The following is a description of a gene set: Human Gene Set: HP_ABNORMAL_CONJUGATE_EYE_MOVEMENT Abnormal conjugate eye movement species: Homo sapiens Any deviation from the normal motor coordination of the eyes that allows for bilateral fixation on a single object., and this is the list of marker genes: GP1BB, ALDH3A2, MAB21L1, RPS26, SOST, FOXRED1, DDX3X, ADSL, METTL27, RRM2B, CDCA7, TGFBR2, NOP56, HECW2, FLNA, LRAT, HADHA, WT1, CACNA1B, KRT10, FGF10, ARL6, UBE3B, UBE2A (ubiquitin conjugating enzyme E2 A), INTS11, COL2A1, ADPRS, MAFB, HACE1, KCNAB2, ATP1A2, PIK3R1, MID1, MDH2, HYLS1, VPS53, TMEM222, SEC23A, POLG, ROR2, PURA, WDR45, EXOSC8, PSMC3, NOG, PTEN (phosphatase and tensin homolog), ATAD3A, FANCD2, NONO (NCBI Gene Id 8253), RHO, EIF4H, NBAS, GAS1, GJA1, BBS1, KRT74, TBCD, DLK1, GTF2I, MT-ND3, MAB21L2, TAF1, MEG3, CDON, NSDHL, AGRN, KANSL1, MRPS34, SUCLA2, DCC, FKTN, PEX13, WARS2, RBM8A, ATIC, GJA8, GRM1, RET, SLC12A6, CEP41, DLL1, POLR1C, FBLN5 (NCBI Gene Id 11268), PHF21A, ADAMTS15, DOCK6, PIGQ, MT-ND1, BCL11A, VPS50, GAN, WDPCP (WD repeat containing planar cell polarity effector), GALNT2, BCOR, NDUFB9, TBC1D7, ATP6V1A, ANAPC7, MED11, HDAC8 (histone deacetylase 8), SNRPN, PEX19, H4C9, PEX11B, GNA14, RBPJ, HOXA1, BCAP31, SON, ASXL3, EP300, BBS10, HMGB3, ACBD6, NT5C2, NDST1, ATR, PALB2, SLC37A4, NDUFB11, MPDU1, PPP1R21, RPL31, GALC, FANCB, MED13, TRPM3, SRPK3, MT-ATP8, NIPBL, POLR3B, CPLANE1, EXT2, DCTN1, IFT172, DPF2, CHN1, NAGA, AIMP1 (NCBI Gene Id 9255), GRIN1, NR2F1, SOS2, ADAT3, CACNA1F, CHAMP1, SLC24A1, NSMF, PIGV, HOXA13, AHCY, ARHGAP31, MAPT, CFAP418, SCLT1, CASK, SCN4A, GNB1, BRCA2, TAF2, UFD1, RNF113A, LARGE1, HNRNPH1, TMEM67, LYRM7, TRIM32, DHX37, BICRA (NCBI Gene Id 29998), RPL9, SLC1A3, CEP19, EHMT1, EIF2S3, CLTRN, BLOC1S3, CAPRIN1, TTI1, SMARCB1, ALDH1A3, COLEC11, FOXL2, SIK1, IDH3A, AHDC1, LRRC32, PRDM16, POU3F4, NDUFS8, KDM5B, DGUOK, HSPG2, PEX3, B9D2, UBA2, EZH2, CLTCL1, SYNE1, SLC9A7, CDH3, SETX, ERI1, SLC6A8, ARVCF, PIBF1, LCA5, CLDN16, ZFX, RIC1, VPS51, CDH2, SIGMAR1, PRSS56, SCAF4, TARDBP, NDUFAF5, PHOX2B, SPTLC1, SCAPER, NOTCH1, AARS1, COG8, RPGRIP1, NDUFS3, GDF5, VCP, FMR1 (fragile X messenger ribonucleoprotein 1), ROBO1, PIGL, TBC1D24, MKS1, ATCAY, PRMT7, KAT8, MYH3, ATP9A, RAI1, MFRP, MN1, ANKH, PEX12, H4C11, MED25, PTPN11, FANCC, IGF1R, KDM6A (NCBI Gene Id 7403), SATB2, NF1, RASA2, CLCN4, NDUFAF8, STRADA, BRPF1, HOXB1, ACOX1, GNB3, XRCC2, SOX3, NDUFA1, NHLRC2, UBE4B, RPL35A, VPS13B, RERE, PEX16, GJA5, ATOH7, RAX (retina and anterior neural fold homeobox), XPC, CYB5R3, PRKAR1B (NCBI Gene Id 645590), MT-ND2, RPL27, ALG2, CRPPA, DEAF1, FOXC1, BMP4, GFPT1, ADD3, TCTN3, RPS27, COL8A2, FKRP, AP3D1, TMEM63C (NCBI Gene Id 57156), BBS4 (NCBI Gene Id 585), DDHD2, PEX2, GRID2, POMK, MKRN3, MAP2K2, NRAS, HPS3, SBF1, DACT1, BBS7, SIL1, MADD, NDUFS2, FARS2, SREBF1, SPTAN1, POLR1D, GPR143, CTBP1, ABCB7, DNMT3A, NRXN1 (NCBI Gene Id 9378), SNIP1, SPEN, CEP85L (centrosomal protein 85 like), ROBO3, SMC1A, PDE6B, NRCAM, TRIP12, SALL4, CACNA2D4, TCF4, U2AF2, AGTPBP1, RPE65, CLCN6, NDUFAF2, CDC42BPB, PCYT1A, PRNP, INPP5K, SMAD3, PIGW, NPAP1, ALG9, UBE3A, IRF2BPL, SEC24C, TASP1, DLL4, ANKRD11, ACO2, TCF20, RPS20 (ribosomal protein S20), HERC2, ALDH18A1, RP1L1, SCN8A, CHD6, EBF3 (NCBI Gene Id 276717), PAX6 (NCBI Gene Id 5080), VRK1, SHANK3, TBX4, ELOVL4, FUS, ASH1L, LAMB2, NSUN2, TEFM, ADAMTS3, PMM2, RAD21, CHRNG, PRKACA, PAH, PTRH2, GLI1, AMMECR1, KCNV2, ATP5F1E, COMT, TOGARAM1, OPHN1, WASHC4, GMPPB, HNRNPU, DDX59, FANCA, NFU1, ALDH4A1, MKKS, COL11A2, KDM5C, KCNC3, LRPPRC, CLP1, FLI1, CTDP1, PDPN, LYST, BRIP1, AHI1, GRM6, MRPL39, AASS (aminoadipate-semialdehyde synthase), CARS1, RREB1, UBE2T, NDUFB10, PNPT1, SLC25A22, GNB2, EXOSC1, OSGEP, PI4KA, RPL10, CASZ1, BAZ1B, NKX6-2, SLC38A8, ARPC4, NEDD4L, GRIA1, MAP2K1, TMEM126A, PLK4, HSPD1, NMNAT1, OFD1, TUBB2B, ARL13B, CAMK2G, EIF4A2, DAB1, TRIM37, ADA2, SLC2A1, ERCC3, MCM3AP, GRHL2, OPA1, OTUD5, LRIT3, FA2H, PIGT, NXN, BEST1, SLC35A2, TELO2, GABRD, BBS12, COL13A1, GPC4, SLC32A1, ALG12, HPDL, FAM50A, ZEB2, ARID1B, KCNE5, HHAT, ZNF423, SETBP1, GATAD2B, MPLKIP, NDUFAF3, PEX6, SCO2, ATP6V0A2, PEX10, HPS6, CNOT3, TMEM240, ATP5F1D, THOC2, SLC16A2, HNRNPR, RNF2, TUBGCP4, MAN1B1, CAMK2A, TMEM218, NPHP1, TBX1, PROKR2, NDUFAF1, PEX26 (peroxisomal biogenesis factor 26), COG1, LGI4 (leucine rich repeat LGI family member 4), BUD23, TUBA1A, TRIT1, NTNG2, SARDH, GMPPA, CC2D2A, SOX2, UNC80, ZSWIM6, TFAP2B, TRPM1 (NCBI Gene Id 4308), MCTP2, CABP4, CACNA1A, ALX4, TYR, IL1RAPL1, ASCL1, ALG11, CRB1, ATP6V1E1, TRAF3IP1, DCN, ABCD1, PAK1, SLC25A4, TANGO2, CLIP2, TET3, TUBB3, PPM1D, ARMC9, ALG6, CCNQ, SLC35C1, POMT2 (protein O-mannosyltransferase 2), FBXW7, SMARCD1, DHCR24, TNPO2, LRP5, FZD5, ACOX2, FTL, CDKL5, TBCK, AP4M1 (NCBI Gene Id 9179), PRKCZ, FAM149B1 (NCBI Gene Id 317662), KIDINS220, MACF1, CPLX1, PTCH2, LZTFL1, SIN3A (NCBI Gene Id 25942), LMNB1, HUWE1 (NCBI Gene Id 54789), RFC2, YY1, SOX11, CA8, WDR35, COL11A1, GJC2 (gap junction protein gamma 2), PLP1, SOS1, KIF15, EVC2, PGAP2, DMXL2, AP4S1, KMT2D, NCF1, KIAA0586, CHCHD10, DYRK1A, FGFR3, MYOD1, GBA1 (NCBI Gene Id 82008), ZIC1, PPP2R5D, PIGU, CDK13, CEP104, UBAP1, MYO9A, TOR1A, ERCC2, ATP5MK (NCBI Gene Id 84833), ADNP, TUBGCP6, SHOC2 (SHOC2 leucine rich repeat scaffold protein), SHMT2, SYT2, XPA, TBC1D2B (TBC1 domain family member 2B), FN1, GK, LPAR6, APC2, B9D1, JAG1, RPL8, ANKRD17, ATP8A2, NSD2, AGK, KIF7, IQSEC2, SLC25A46, ALDH7A1, STT3A, HMX1, SCNM1, PITX2, GNAT1, PLPBP, CBY1, ASNS, PBX1, BLTP1, RPL18, SHROOM4, FANCE, ZNF408, CAMK2B, RAB3GAP2, ZEB1, MRAS, COL6A1, GTF2IRD1, BLOC1S5, EIF2AK2, KRT71, RNH1, ARCN1, BBS2, NALCN, CCDC28B, PIGO, NANS (N-acetylneuraminate synthase), KAT5, SYNJ1, NDUFV1, CTNNB1, IFT27, AUTS2, SLC25A24, NDUFA6, MTOR, RPS28, GATA1, PHGDH, RHOA, AFF4, SUCLG1, FKBP6, OTX2, CWF19L1, CEP152, SRRM2, COL6A3, PACS1, LETM1, TCEAL1, CTCF, RRAS2, NDUFS4, NAA60, RPS6KA3, SLC25A1, SOX5, AFF3, CYP1B1, DNMBP, RTL1, EXOC8, GLI2, MAGEL2, SMARCA4, GRM7, BCORL1, PLA2G6, PIEZO2, FGFR2, PPP1R12A, FZD2, LARP7, ATXN1, TTC8, CHST3, ATP1A3, CRIPTO, EXOSC2, DOLK, TIMM50, CACNA2D2 (NCBI Gene Id 9254), FZD4, GRK1, BPTF, POLR1A, NEUROD2, TKT, CHRNA7, DLG4, MAP3K7, KCNJ13, INPP5E, AEBP1, USP9X, CYB5A, RPL11, KDM1A, DHODH, PTCH1, KAT6A, CSPP1, ATP5F1A, RECQL4, WDR11, KMT2A, PACS2, CAMTA1, ERF, POMGNT1, PSAP, USP7, HLA-DQB1, TMEM126B, ARID2, SYNGAP1, OCRL, NPC1, ABCC8, TRIM8, PNPLA6, BCAS3, FIBP, ALG1, MED12, SAG, AMPD2, THG1L, MTFMT, RNASEH1, FRMPD4, KIAA0753, WBP4, SKI, NDUFA11, YARS2, MAD2L2, FOXP1, ZIC2, KDM6B, COL25A1, NGLY1, LMBRD2, VLDLR, NAXE, LIMK1, TRIM44, PWRN1 (Prader-Willi region non-protein coding RNA 1), MECR, EXOSC5 (exosome component 5), CRYAA, SPECC1L, TMEM270, ATP6V1B2, CBL, TCTN1, KIF21A, OVOL2, RAB11B, AFG2A, AP4B1, ZMIZ1, EMC1, NELFA, ARNT2, CNTNAP2, DPYSL5, TGFBR1, TIMMDC1, ATM, SMARCC2, UFC1, ATP13A2, SNAP25, PIGY, HNRNPH2, POLR1B, CDC42, SIAH1, ERCC1, SCUBE3, ABCC9, SLC18A3, TARS1, SUFU, SLC39A8, FANCM, DHCR7, RS1, RAD51C, TFE3, ARHGEF2, TGIF1, TBL2, AP1S2, H4C5, TFAP2A, BRD4, SPG7, GOLGA2, ACADSB, ERCC4, LZTR1, BBIP1, POLR3A, YME1L1, SYT1, TMEM53, ARID1A, RSPRY1, RPL35, FGD1, LARS2, COG3, NSD1, MMP23B, RMRP, GLRX5, GTF2IRD2, TRAPPC6B, SHH, WDR81, COL12A1, MC1R, COL18A1 (collagen type XVIII alpha 1 chain), DNAJC30, EFNB1, ADGRG1, KIF22, P4HTM, DHX30, PCDHGC4, NODAL, GGT1, SF3B4, HID1, WASF1, DVL3, TGFBI, SNORD116-1, ACKR3, RPGRIP1L, PRPS1, PIGG, RBL2, FIG4, TMEM98, PWAR1, AP4E1, TLK2, ERCC8, CHST14 (carbohydrate sulfotransferase 14), TMEM216, SIX3 (NCBI Gene Id 6496), HRAS, ALX3, SDCCAG8, GTF2E2, BBS5, NDUFS7, METTL5, NPC2, PQBP1, FGF3, CDH11, ATPAF2, SOX4, PLOD1, MPDZ, ABHD5, WDR73, ERCC6, EBP, ATRX, AP3B1, BRAF, H1-4, NEU1 (neuraminidase 1), CACNA1G (NCBI Gene Id 8913), DDB1, ALG3, PIK3R5, HK1, NDUFS1, ERMARD, CDK10, STX1A, CEP83, JMJD1C, MYT1L (myelin transcription factor 1 like), MAPK8IP3, TMEM138, PRKACB, RPS29, GATA4, PAX3, SOBP, FBXW11, SIX6, SCN1B, LONP1, MAN2B1, GTF2H5, COL4A1, ATP2B3, FANCI, CD96, TSR2, FGFR1, SNORD115-1, LIPH, MTRFR, POLR2A, FBXO11, DDX6, ZDHHC9, EIF2AK3, GNAO1, RPS15A, GMNN, PEX5, CBS, RRAS (NCBI Gene Id 6237), SIM1, ORC1, TAOK1, PIGP, ZC4H2, TMCO1, CHD7, CCDC174, DKC1, DPP6, SALL1, TOPORS, SF3B2, RPL26, EVC, ZNF292, LBR, POLRMT, RPS19 (NCBI Gene Id 8378), GLRB, CENPJ, ITPR1, L2HGDH, ATG7, LRMDA, KMT2B, BBS9, MEF2C, PEX1, GJB6, NUP133, VPS13A, HSD17B4, NDP, MRPS2, HEATR3, EOGT, PGAP3, FBXL4, CHAT, NDUFAF4, FGF14, CDC45, ZBTB20, RFWD3, SLC5A7, SAMD9L, WNK3, ASCC3, WAC, EXOSC9 (NCBI Gene Id 5393), RPS10, SQSTM1 (sequestosome 1), ERCC5, OCA2, NEK9, KDM5A, GRIA4, POMT1, SUPT16H, POU4F1, HESX1, SLC44A1, DISP1, INTS1, RPS7, SMG8, NHS, KCNN2, LMX1B, DDB2, B3GALNT2 (beta-1,3-N-acetylgalactosaminyltransferase 2), RAB39B, FRMD4A, FOXH1, CHD8, AP1G1, DOHH, PEX14, ISCA1, KATNIP, CPSF3, FOXE3, LAMA1, RORA, SPTBN2, CRELD1, MYO5A, DVL1, PAK2, SPOP, FANCG, ZNF407, VPS37D, FCSK, COL6A2, BAP1, MLXIPL, BRCA1, CHD3, DPYD, LUZP1, GGCX, HIRA, TYRP1 (NCBI Gene Id 7306), POLA1, PRSS12, SPTBN1, NEXMIF, MAPRE2, MYO1H, SPRED2, SPATA7, AKT1, CRIPT, FBN1, REV3L, PYROXD1, PRDM13, SMAD4, NCDN, TCTN2, GRIK2, PIGN, CDK8, DDOST, ARX (NCBI Gene Id 619216), EIF3F, SRCAP, PLXNA1 (plexin A1), MID2, SETD5, FLII (NCBI Gene Id 2314), IARS2, TDO2, ANTXR1, ELN, PLXND1, B3GAT3, PRR12, SLC6A19, COL4A2, MCOLN1, KLF13, EXOSC3, PDCD6IP, IFT74, IKBKG, AGO1, CLDN19, NDN, PRKAR1A, AGO2, PYCR2, TWIST1, RAD51, TKFC, DNM1L, PHIP, TBC1D23, TMEM231, TTI2, FOXP2, DPM1, RIT1, TREX1, PDE4D, SLC17A5, MBD5, NYX, APC, TSEN15, CLCN3, FGFRL1, H3-3A, TENM3, DLAT, SLX4, C9orf72, YAP1, MYF5, DPAGT1, FANCF, SCN2A, TRAF7, VAMP1, RPL5 (ribosomal protein L5), TRIP11, PUS7, PUS3, NDUFB3, FANCL, COL1A2, NUBPL, TCF12, TBK1, RAB23, CLDN11, FBXO28, WDR26, EDEM3, CHMP1A, FGF8, TWIST2, CEP120, NFIX, TRAPPC11, STAG1, ARL3, RNU4-2, COG5, RPL15, PDE6D, TMEM94, FRMD5, SLC30A9, DSE, CHRNE, SSR4, DPM2, SMG9, RAF1, ADARB1, SLC9A6, HIBCH, ERLIN2, UBR1, MED13L, WNT5A, SET, FBXL3, TRIO, POGZ, UBAP2L, PAX2, TBL1XR1, KCNA1, GNAQ, ACSL4, TWNK, NDUFV2, PIDD1, MT-ATP6, H4C3, SALL2, KIF14, PORCN, MUSK, CTSK, PHOX2A, SEMA3E, MEGF8, PNKP, LAGE3, CCDC88C, PSMD12, KCNMA1, KRAS, CREBBP, NDUFS6, DLG3, TCOF1 (treacle ribosome biogenesis factor 1), SMC3, PUF60, DYNC2LI1, VSX1, KRT25, TBX15, UFSP2, COQ8A, ALS2, L1CAM, STXBP1, BRF1, SLC2A10 (NCBI Gene Id 81031), SPG11, CEP290, RNF135 (NCBI Gene Id 84282), TMEM237, GPR179, MED12L, SMARCE1, ASXL1, HPS5 (NCBI Gene Id 246309), SGPL1, GNAS, RPS24, LIG4 (NCBI Gene Id 3981), TAF6, PGM2L1, NCAPG2, RPS17